Given this list of marker genes UCHL1, RPS27A, UBA52, UBC, UBB, here is a description of the gene set: species: Homo sapiens Pathway Definition from KEGG: UB(chain) -- UCHL1 -> UB(free) UCHL1-mediated hydrolysis. Pathway ID: N01027. Pathway type: Reference. Pathway class: nt06463 Parkinson disease. Human Gene Set: KEGG_MEDICUS_REFERENCE_UCHL1_MEDIATED_HYDROLYSIS